The following is a description of a gene set: Any process that modulates the frequency, rate or extent of signal transduction mediated by the JNK cascade. studied in species Homo sapiens Human Gene Set: GOBP_REGULATION_OF_JNK_CASCADE, and this is the list of marker genes: TLR4, RGS2, TNFSF11, MAPK8IP1, GRIK2, MIR92A1, CCN2, AGER, STK3, PINK1, IGF1R, NOD1, FKTN, HMGB1, COPS5, MAPKBP1, MFHAS1, RIPK2, HIPK3 (NCBI Gene Id 10114), TNIK, DACT1 (dishevelled binding antagonist of beta catenin 1), MDFIC, MBIP, RNF13, KLHL31, TLR3, MAPK8IP3, LTBR, AIDA, PLCB1, ITCH, FGF19, TLR9, NCOR1, DKK1, F2RL1, ZNF622, FZD7 (NCBI Gene Id 8324), APP, IL1B, ZNF675, CCL19, BIRC7, SEMA3A, SIRPA, UNC5CL, MEN1, ANKRD6, MAPK8IP2, MECOM, GADD45A, RB1CC1, TIRAP, DVL2, TNFRSF11A, XIAP, PHLPP1, CD27, TNF, MTURN, GSTP1, TRIB1, TGFBR3, MAP3K5 (NCBI Gene Id 4217), TNXB, ULK4, CBS, SLAMF1, PTPN22, SDCBP, SERPINB3, SH3RF1, CCL21, DUSP10, WNT7B (NCBI Gene Id 7477), TRAF2, TNFRSF19, SH3RF3, SH3RF2, MAP3K11, MYD88, DUSP19, TAOK2, NOD2, CYLD, GADD45B, DNAJA1, DUSP3, PJA2, TPD52L1, EDA2R (NCBI Gene Id 60401), ENSG00000274276, NPPA, CRACR2A, TRAF4, PYCARD, PRKN, HDAC3, FCGR2B, TAOK1, PTK2B, HRAS, CCDC88C, MAP4K2, DVL3, NR2C2, WNT16, TRPV4, CRK, AXIN1, MAP3K10, EPHB1, DAB2IP, PRMT1, TRAF6, MDFI, MYOC (myocilin), WNT7A, EDN1, PDCD4, EDAR, FLT4, MARVELD3, RAP2A, HIPK2, MAP4K4, TAOK3, SERPINF2, PAFAH1B1, EPHA4 (EPH receptor A4), CARD9, MDFIC2, NOX1 (NADPH oxidase 1), NAIP, WNT5A (Wnt family member 5A), GADD45G, ZMYND11, GPS2, RASSF2, NRK, PER1, RIPK1, CCR7, MINK1, FZD10, DUSP22, MAP2K7, AMBP